The following is a description of a gene set: species: Homo sapiens PI Metabolism Human Gene Set: REACTOME_PI_METABOLISM, and this is the list of marker genes: PLEKHA6, PI4K2A, MTMR1, PIK3CG, TPTE2, INPP5D, PLEKHA5, MTMR3, PIP4K2C, PIK3C2A, INPP5E (NCBI Gene Id 56623), MTM1, INPP5F, PIK3C2G, PI4KA, INPP4B, MTMR2, MTMR14, PNPLA7, TNFAIP8L1, INPP5J, RAB14, PIP4K2A, MTMR7, TPTE, INPPL1, SBF2, SYNJ2, MTMR9, PI4K2B (phosphatidylinositol 4-kinase type 2 beta), PIP5K1B, PITPNB, INPP4A, FIG4, VAC14, MTMR8, ENPP6, PI4KB, PIP5K1C (NCBI Gene Id 23396), PIK3CD, PIK3R6, PIK3R4, MTMR6, PIP4P1, MTMR12, PIKFYVE, PIK3R1, PTPN13, PNPLA6, PLEKHA8 (NCBI Gene Id 84725), TNFAIP8L3, PIK3C3, SACM1L, MTMR4, PLEKHA4, GDPD1 (glycerophosphodiester phosphodiesterase domain containing 1), GDPD5, OCRL, SYNJ1, PIP5K1A, SBF1, ARF3, PLEKHA1, PIK3R5, PIK3R2, ARF1, GDE1, PIK3CB, BMX, RAB4A, PIK3CA, PTEN, RAB5A, MTMR10 (myotubularin related protein 10), INPP5K, TNFAIP8, PIK3C2B, GDPD3, PLEKHA3, PLEKHA2, PIP4K2B, RUFY1, PIK3R3, TNFAIP8L2